The following is a description of a gene set: A spliceosomal complex that contains three snRNPs, including U5, bound to a splicing intermediate in which the first catalytic cleavage of the 5' splice site has occurred. The precise subunit composition differs significantly from that of the catalytic step 1, or activated, spliceosome, and includes many proteins in addition to those found in the associated snRNPs. species: Mus musculus Mouse Gene Set: GOCC_CATALYTIC_STEP_2_SPLICEOSOME, and this is the list of marker genes: Isy1, Aqr, Syf2, Bud31, Wdr83, Tex16, Hnrnpk, Zcchc8, Ppie, Snrpa1, Snrpd1, Sart1, Pnn, Snw1, Alyreffm8, Alyreffm11, Rbm22, Cwc22rt3, Hnrnpa2b1, Alyref2, Snrpd2, Ddx23, Lsm7, Dhx35, Alyreffm4, Cwc15, Slu7, Snrnp40, Cdc5lrt4, Snrpert, Cdc5lrt10 (cell division cycle 5 like, retrotransposed 10), Rbmx, Cdc5lrt8, Cwc22rt1, Ppwd1 (peptidylprolyl isomerase domain and WD repeat containing 1), Cdc5lrt1, Rbm44, Plrg1, Magohb, Syncrip (synaptotagmin binding, cytoplasmic RNA interacting protein, NCBI Gene Id 78260), Eftud2, Gpatch1 (NCBI Gene Id 67471), Snrpe, Srsf1, Cdc5lrt6, Crnkl1, Alyreffm9, Cwc27 (CWC27 spliceosome-associated protein), Cwc22 (CWC22 spliceosome-associated protein), Alyreffm3, Hnrnpc, Prpf8, Cwc22rt6, Ppil3, Hnrnpa3 (NCBI Gene Id 69921), Alyref, Sf3b1, Snrpg, Cdc5lrt7, Ppil2 (NCBI Gene Id 66053), Alyreffm6, Hnrnpr, Sf3a1, Snrpf, Sf3a2, Prpf6, Hnrnpm, Prpf4b, Tfip11, Raly, Lsm3, Cdc5lrt9, Cdc5l, Cwc22rt2 (NCBI Gene Id 668100), Hnrnph1, Snrpb, Ddx41, Rbm8a2, Cdc40, Srrm1, Lsm2, Ppil1, Eif4a3l1, Frg1, Pabpc1, Dhx38, Prpf19, Ess2, Sf3b3, Snrnp200, Ddx5, Alyreffm5, Cwc22rt5, Mtrex, Snrpb2, Sf3a3, Bcas2, Hnrnpa1, Sf3b2, Eif4a3l2, Eif4a3, Cwc22rt4, Alyreffm1 (Aly/REF export factor family member 1), U2af1, Xab2, Rbm8a, Alyreffm10, Hnrnpu, Srrm2, Alyreffm7, Cdc5lrt5, Snrpn, Snrpd3, Hnrnpf (NCBI Gene Id 98758, heterogeneous nuclear ribonucleoprotein F), Rbmxl1, Cwc22rt7, Dhx8, Cactin, Magoh